The following is a description of a gene set: Human Gene Set: GOMF_PHOSPHATIDYLINOSITOL_4_PHOSPHATE_BINDING species: Homo sapiens Binding to phosphatidylinositol-4-phosphate, a derivative of phosphatidylinositol in which the inositol ring is phosphorylated at the 4' position., and this is the list of marker genes: SNX3, PLEKHA3, SH3PXD2A, JPH2, PLEKHA5, PLEKHA8, WASHC2C, CERT1, GSDMC, SESTD1, PLA2G4E, GOLPH3, PLA2G4A, OSBPL8, NLRP3, GOLPH3L, SAP30L (SAP30 like), OSBPL5, RUBCNL, GSDMD, OSBP, GSDMA, GSDMB, SNX24, SNX5, ARFIP2, OBSCN, DAB2IP, ARFIP1, PLEKHF1, LANCL2